The following is a description of a gene set: species: Mus musculus Mouse Gene Set: GOBP_NITROBENZENE_METABOLIC_PROCESS The chemical reactions and pathways involving nitrobenzene (nitrobenzol), a derivative of benzene with an NO2 group attached to the ring. It is a yellow aromatic liquid used in perfumery and manufactured in large quantities in the preparation of aniline., and this is the list of marker genes: Gstm3 (glutathione S-transferase, mu 3), Gstm7, Gstm4, Gstm5, Gstm6